The following is a description of a gene set: species: Homo sapiens Mineralocorticoid biosynthesis Human Gene Set: REACTOME_MINERALOCORTICOID_BIOSYNTHESIS, and this is the list of marker genes: HSD3B1, HSD3B2, CGA, LHB, CYP21A2 (NCBI Gene Id 1589), CYP11B2